Given this list of marker genes FNBP1, PREX1, CAV1, IQGAP3, SNAP23, GIT2, PIK3R2, OPHN1, TFRC, GJA1, MPP7, DIAPH3, NIPSNAP2, CDC42, ARHGAP35, PAK1, ARHGAP5, RHOJ, ARHGAP1, PIK3R1, RAB7A, ARHGAP26, VAMP3, STOM, DOCK8 (dedicator of cytokinesis 8), TRIO, WWP2 (NCBI Gene Id 116013), FNBP1L, ARL13B, WASL (NCBI Gene Id 8976), PAK2, PAK4, ARHGAP32, CPNE8, CDC42BPB, GIT1, OCRL, TMPO, WIPF2, CDC42EP1, WAS, ARHGAP21, VANGL1, CDC42BPA, SCRIB, DEPDC1B, PAK3, JUP, FMNL3, STEAP3, SLC4A7, SYDE1, LAMTOR1, ARHGEF7, SLC1A5, here is a description of the gene set: part of: RHO GTPase cycle This pathway catalogues RHOJ (also known as TCL or RHOI) guanine nucleotide exchange factors (GEFs), GTPase activator proteins (GAPs), and RHOJ effectors. No GDP dissociation inhibitors (GDIs) have been shown to interact with RHOJ. RHOJ, together with RHOQ (TC10), belongs to the CDC42 subfamily of RHO GTPases and shares 85% and 78% amino acid similarity with RHOQ and CDC42, respectively. RHOJ regulates the cytoskeleton, including formation of lamellipodia and actin filaments. RHOJ is highly expressed in endothelial cells, regulating their motility and, consequently, vascular morphogenesis. As a part of the VEGF signaling cascade, RHOJ promotes retinal angiogenesis. RHOJ plays a role in cancer cell migration and cancer-related angiogenesis. RHOJ is involved in adipocyte differentiation. species: Homo sapiens Reactome Pathway: RHOJ GTPase cycle